Given this list of marker genes ARHGAP42, ORMDL3, DMD, JPH4, TNNT1, GSTO1, DLG1, CACNA1S, SLC8A1, GPER1, EDN3 (NCBI Gene Id 1908), STUB1 (STIP1 homology and U-box containing protein 1), GATA4, DSC2, ADRA1B, TNNT3, PROK2, CAMK2D, AKAP9, JUP, ADRA2A, CHGA (NCBI Gene Id 1113), ADRB2, PPP1R12B, ADA, DOCK4, ADRA2C, TBXA2R (NCBI Gene Id 6915), MYH7B, ZC3H12A, GUCY1A1, CACNG1, NKX2-5, KIT, MYL3, SMAD7, CACNB1, PIK3CG, CALM3, GRK2 (G protein-coupled receptor kinase 2), EDN1, CHRM3, PRKG1, REM1, SCN4A, CAV1, PLN, CACNA1C (calcium voltage-gated channel subunit alpha1 C), CNN1 (calponin 1), SCN10A, F2R, SCN5A, ZDHHC21, CACNB2, KCNQ1, ADCY10, ATP2A1, GHSR, CTNNA3, MIR30E, GHRL, C12orf57, TMEM38B, JPH2, P2RX4, RHOA, SETD3, TRPV4 (transient receptor potential cation channel subfamily V member 4), MIR1-1, TRPM4, ACE2, KCNA1, MAP2K1, GSTM2, ITGA2, MIR153-1, SPX, DMPK, SRF, CAV3, BMP10, UCN, MYBPH, PKP2, GJA5, TNNI3K, JPH3, RGS2, DSG2, ANXA6, ABAT, PRKACA, CTTN, SLC8A3, TACR3, KCNJ2, NPPA, MIR448, EHD3, MYLK2, STRIT1, SOD1, EDN2, MIR143, NPNT, KCNB2, ASPH, MIR21, NMU, ATP2B1, PRKD1, CALCA, SRI, TMEM38A, TNNC2, CALM1, HRC, TACR1, SPHK1, CASQ1, SUMO1, DSP, MIR133A1, MYL9, MYBPC3, DAPK3, MYL5, TACR2, ADRA1A, FKBP1A, PDE4D, ADGRD1, ACTN3, FGF13, IRAG1, HSP90AA1, ATP1A2, CLIC2, RNF207, ATP1A1, BIN1, ADRA2B, ATP1B1, TNNC1, NPY2R, MIR145, FKBP1B, PDE4B, MYL2, NOS1, TNNI1 (NCBI Gene Id 7135), MYOCD, ADORA1, HCN4, KBTBD13, P2RX1, ANK2, TRDN, RANGRF, STC1, CHRM2, JPH1, NMUR2, TNNT2, CHRNB4, DOCK5, SLC9A1, ENO1, MIR200C, TNNI3, OXT, CHRNA3, CALM2, ADORA2B, ATP2A2, RYR2, MYH7, TPM1, CASQ2, here is a description of the gene set: Human Gene Set: GOBP_REGULATION_OF_MUSCLE_CONTRACTION species: Homo sapiens Any process that modulates the frequency, rate or extent of muscle contraction.